Given this list of marker genes Fbxw11, Gjd2, Asb4, Ankrd33b, Pdzrn3, Acot11, Hspa12a, Dnase1l1, Zfp955a, Tnfaip2, Pbx1, Ufsp1, Zfp955b, Man1b1, Kcnf1, Tfap2b, Tspyl5, Mtmr2, Nav1, Tomm20 (NCBI Gene Id 67952), Gm20604, Nrcam, Upp2, Krt32, Ndufv2, Phex, Mtss1, Ino80d, Eya4, Ldlrad3 (low density lipoprotein receptor class A domain containing 3), Cyp1b1, Cartpt, Ldb2, Nphs2, Zfp266, Xpr1, Edem3, Mecp2, Spata2l, Moap1, St6gal1, Ccdc127, here is a description of the gene set: species: Mus musculus Mouse Gene Set: MIR_7066_3P Genes predicted to be targets of miRBase v22 microRNA mmu_miR_7066_3p in miRDB v6.0 with MirTarget v4 prediction scores > 80 (high confidence targets). from publication Chen Y, Wang X (PMID 31504780)